Given this list of marker genes Lyz2, Klf2, Limd2, Naca, Cybb, Ptpn18, Arl5c, Hspa1b, Gltp, Vnn3, Tppp3, Abi3, Tsc22d4 (NCBI Gene Id 78829), Camk1d, Sptssa, Cx3cr1, Hpse, Pdlim1, Cox7a2l, Rgs2, Clec2i, Fos, Insr, Slc29a1, Gpsm3 (NCBI Gene Id 106512), Lyl1 (lymphoblastomic leukemia 1), Abcg1, Spn, Stk24, Hspa1a, Stk38, N4bp2l1, Ankrd44, Rgs10, Npc2, Abca9, Pld4, Selplg (selectin, platelet (p-selectin) ligand), Coro1a, Nxpe4, Eef1b2, Adgre5, Tnfaip8l2, Cd300a, Ifngr1 (NCBI Gene Id 15979), B3gnt8, Tmem59, Eef1a1, Ucp2, Cd48, Lrwd1, Arhgef18, Cyp27a1, Lrrc20, Eif3h, Rasgrp2, Dipk1a (divergent protein kinase domain 1A), Sowahc, Add3, Zfp36l2, Mbnl1, Slc38a2, Crip1, Rassf4, Sh3bgrl3, Hacd4, Rras, H2-K1, Lmo1, Nfix, Eif3f, Meaf6, Serinc3, Ldlrad3, Plxdc1, Ctdsp2, Bri3, Sat1, E2f8, Glipr1, Lst1, Itm2b, Nr4a1, Jund, Mbp, Fau, Tmcc1, Susd3, Gngt2, Gpx1, Fcgrt, Lsp1, Btg2, Fosb, Higd2a, Cep97, Hpgd, Il16, Cep57l1, H2az1, Cdc42ep3, Plxnd1, Ankrd10, Klf4, Eef2, Arhgap45, Ypel3, Impa2, here is a description of the gene set: Cytokines mediate cell-cell communication in the immune system and represent important therapeutic targets. A myriad of studies have highlighted their central role in immune function, yet we lack a global view of the cellular responses of each immune cell type to each cytokine. To address this gap, the authors created the Immune Dictionary, a compendium of single-cell transcriptomic profiles of more than 17 immune cell types in response to each of 86 cytokines (>1,400 cytokine-cell type combinations) in mouse lymph nodes in vivo. A cytokine-centric view of the dictionary revealed that most cytokines induce highly cell-type-specific responses. For example, the inflammatory cytokine interleukin-1β induces distinct gene programmes in almost every cell type. A cell-type-centric view of the dictionary identified more than 66 cytokine-driven cellular polarization states across immune cell types, including previously uncharacterized states such as an interleukin-18-induced polyfunctional natural killer cell state. studied in species Mus musculus from publication Cui A, Huang T, Li S, Ma A, Pérez JL, Sander C, Keskin DB, Wu CJ, Fraenkel E, Hacohen N (PMID 38057668) Genes negatively differentially expressed in cell type: Monocyte upon treatment with cytokine: IL-36α in mouse lymph nodes in vivo. Mouse Gene Set: CUI_MONOCYTE_IL36A_RESPONSE_DN